The following is a description of a gene set: Human Gene Set: HP_BOWEL_DIVERTICULOSIS The presence of multiple diverticula of the intestine. studied in species Homo sapiens Bowel diverticulosis, and this is the list of marker genes: UBR1, PIK3CA, BAZ1B, ERBB3, FKBP6, LTBP1, STAT3, GTF2IRD2, NCF1, RFC2, AKT1, PKD1 (NCBI Gene Id 5310), EFEMP2, LIMK1, EIF4H, GTF2IRD1, MLXIPL, DNAJC30, METTL27 (methyltransferase like 27), COL5A1, ELN, RET, MSH2, ALDH18A1, TBL2, EFEMP1, CLIP2, PTEN, TYMP, GTF2I, BUD23, FBLN5, VPS37D, MLH1, STX1A, TMEM270, POLG